The following is a description of a gene set: species: Mus musculus Mouse Gene Set: REACTOME_PHASE_2_PLATEAU_PHASE Phase 2 - plateau phase, and this is the list of marker genes: Cacnb2, Kcne4, Cacng8, Cacna1c, Kcne5, Cacng7, Cacng6, Kcne3, Kcnq1, Cacnb1, Akap9, Cacna2d2, Cacng4, Kcne2